The following is a description of a gene set: Microautophagy (MI) is a non-selective autophagic pathway that involves internalisation of cytosolic cargo through invaginations of the lysosomal membrane. MI can be induced by nitrogen starvation and complements other related self-eating processes such as Macroautophagy (MA) and Chaperone Mediated Autophagy (CMA). MI can degrade cell organelles and bulk cytosolic proteins directly via the lysosome and late endosome. MI can also target substrates with KFERQ motifs with the help of HSPA8 (Li W W et al. 2012). species: Homo sapiens part of: Autophagy Reactome Pathway: Late endosomal microautophagy, and this is the list of marker genes: CFTR, PLIN2, CHMP4B, CHMP4A, CHMP6, VPS37A, PCNT, CHMP4C, PLIN3, ARL13B, HBB, TSG101, VPS37C, IFT88, VIM, CETN1, MVB12A, HSPA8, HDAC6, VPS37B, RNASE1, UBC, CHMP7, CHMP2B, CHMP2A (NCBI Gene Id 27243), UBA52, VPS28, VPS37D, PARK7, RPS27A, CHMP3, UBAP1 (NCBI Gene Id 51271), UBB, MVB12B